The following is a description of a gene set: DNA methylation is essential for normal development and has been implicated in many pathologies including cancer. Our knowledge about the genome-wide distribution of DNA methylation, how it changes during cellular differentiation and how it relates to histone methylation and other chromatin modifications in mammals remains limited. Here we report the generation and analysis of genome-scale DNA methylation profiles at nucleotide resolution in mammalian cells. Using high-throughput reduced representation bisulphite sequencing and single-molecule-based sequencing, we generated DNA methylation maps covering most CpG islands, and a representative sampling of conserved non-coding elements, transposons and other genomic features, for mouse embryonic stem cells, embryonic-stem-cell-derived and primary neural cells, and eight other primary tissues. Several key findings emerge from the data. First, DNA methylation patterns are better correlated with histone methylation patterns than with the underlying genome sequence context. Second, methylation of CpGs are dynamic epigenetic marks that undergo extensive changes during cellular differentiation, particularly in regulatory regions outside of core promoters. Third, analysis of embryonic-stem-cell-derived and primary cells reveals that 'weak' CpG islands associated with a specific set of developmentally regulated genes undergo aberrant hypermethylation during extended proliferation in vitro, in a pattern reminiscent of that reported in some primary tumours. More generally, the results establish reduced representation bisulphite sequencing as a powerful technology for epigenetic profiling of cell populations relevant to developmental biology, cancer and regenerative medicine. Genes with high-CpG-density promoters (HCP) that have no histone H3 methylation marks in brain. Human Gene Set: MEISSNER_BRAIN_HCP_WITH_H3_UNMETHYLATED species: Mus musculus from publication Meissner A, Mikkelsen TS, Gu H, Wernig M, Hanna J, Sivachenko A, Zhang X, Bernstein BE, Nusbaum C, Jaffe DB, Gnirke A, Jaenisch R, Lander ES (PMID 18600261), and this is the list of marker genes: DES, DDX4, DPEP3, HORMAD1, MAEL, PDHA2, TNFRSF25, OMP, NSMCE3, PHETA2, MSH4, ACTL7B, NPB, HSF5, C19orf67 (chromosome 19 open reading frame 67), CAMKK2, SPO11 (SPO11 initiator of meiotic double strand breaks), TTC22, ADAD1, EPPK1, NAA11, SYCP2 (NCBI Gene Id 10388), PAPOLB, MYCN (NCBI Gene Id 53360), SYCP3, FSTL3, KCNG1, SPEG, TDRD1, MTARC1, BHLHA15, NRK, RNF17 (NCBI Gene Id 56163), SLC25A31, TAF7L, EZHIP, SYCP1, C5orf47, FKBP6